The following is a description of a gene set: Human Gene Set: BURTON_ADIPOGENESIS_12 Strongly down-regulated at 2 h during differentiation of 3T3-L1 cells (fibroblast) into adipocytes. from publication Burton GR, Nagarajan R, Peterson CA, McGehee RE Jr (PMID 15033539) During cellular differentiation and development, it is recognized that many complex molecular mechanisms as well as precise patterns of differentially expressed genes occur in directing precursor cells toward a given lineage. Using microarray-based technology, we examined gene expression across the course of 3T3-L1 adipocyte differentiation. Total cellular RNA was isolated at times 0, 2, 8, 16, 24, 48, and 96 h following treatment with either standard hormonal inducers of differentiation; insulin, dexamethasone, isobutylmethylxanthine (IDX), or IDX plus trichostatin A (TsA), a histone deacetylase inhibitor and potent adipogenic inhibitor. cRNA was synthesized from cellular RNA and hybridized to high density Affymetrix MG_U74Av2 microarray gene chips containing 12,488 cDNA/Expressed Sequence Tags (ESTs) probe sets. From the IDX-only treated cells, all probe sets that were either unchanged or differentially expressed less than 2-fold throughout differentiation with respect to time 0 preadipocytes were excluded from further analyses. This selection resulted in a net of 1686 transcripts, 859 were increased in expression, and 827 were decreased in expression at least 2-fold across differentiation. To focus in on genes that were more specific to differentiation, the same analysis was performed on IDX plus TsA-treated non-differentiating cells and all probe sets from the IDX-only group that exhibited similar expression profiles in the non-differentiating TsA-treated group were excluded leaving a total of 1016 transcripts that were regulated only under differentiating conditions. Six hundred and thirty-six of these transcripts were elevated at least 2-fold and 380 exhibited a decrease in expression relative to time 0 preadipocytes. This group of genes was further analyzed using hierarchical clustering and self-organizing maps and resulted in the identification of numerous genes not previously known to be regulated during adipocyte differentiation. Many of these genes may well represent novel adipogenic mediators and markers of adipogenesis. species: Mus musculus, and this is the list of marker genes: PTBP3, ARGLU1, SRSF10, MKI67, DNAJC3, IREB2, BUB1 (NCBI Gene Id 699), BOD1L1, CASP8AP2, PHF12, ARID1A, GTF2A1, KIF2A, H1-0, FAM76B, RSRP1, MYEF2, KITLG, SP3, CYP1B1, BPNT2, DIPK2A, UBE2V2, CIP2A, NIPBL, SRPK2, CAPN7, EMC2 (NCBI Gene Id 9694), HNRNPM, POLN, TMEM68, ZNF638